Given this list of marker genes ZW10, TAOK3, WAC, MRNIP, INTS7, DGKZ, NSUN2, RPS27L, TAOK2, DNA2, TEX14, MAD1L1, HINFP, BUB1B, IK, STK38, TREX1, RNASEH2B, FBXO4, LYN, MAP3K20 (NCBI Gene Id 51784), TTI1, SPC25, CLOCK, PTPN11, NBN, NOP53, FOXO4, PLK1, CDT1, SYF2 (NCBI Gene Id 25949), SETMAR, CEP63, RFWD3, ORC1, KNTC1, SPDL1, PPP1R10, INCENP, BRD4 (NCBI Gene Id 90616), CDC6, PSMG2, DTL, NDC80, BRCC3, TIPIN, TTK, TPR, CLSPN, MSH2, TELO2, CDK5RAP3, BABAM1, NAE1, INIP, APC, LCMT1, KLHL22, DOT1L, BRIP1, HUS1B, SPC24, STK33, TRIAP1, TIMELESS, ETAA1, BIRC5, BABAM2, WDR76, RINT1, XPC, CRY1, UFL1, MAD2L2, CUL4A, MRE11, PRKDC, CCND1, CDC14B, BUB1, BUB3, RHNO1, CDK1, ZWILCH, SKA3, ATR, RAD17, ATRIP, NUF2, BARD1, PRP4K, RAD9B, MBTPS2, ZFYVE19, HORMAD1, DTX3L, CDK2, FZR1 (fizzy and cell division cycle 20 related 1), PARP9, PRPF19, CCAR2, INTS3, CCNB1, EME1, DUSP1 (dual specificity phosphatase 1), ATM, H2AX, FEM1B, NABP2, MAPK14, RAD51, DYNC1LI1, CDC45, TICRR, SKA1, BRCA1, XRCC3, E2F1, GIGYF2, CENPF (centromere protein F), KNL1, MBTPS1, ERCC6, CHFR, EIF2AK4, PLK3, BLM, CHEK2, RAD50, FANCD2, PROX1, FBXO6, ATF2, HASPIN, USP28, FBXO31, CDC5L, CDC20, TP53 (NCBI Gene Id 7157), TTI2, GEN1, TP53BP1, ABRAXAS1, TAOK1, PABIR1, EME2, RBBP8, RAD1, MAD2L1BP, TIPRL, CDKN1A, RPA2 (NCBI Gene Id 6118, replication protein A2), CHMP4C, DONSON (NCBI Gene Id 55597), MUS81, UIMC1, GNB1L, NABP1, BRCA2, ZWINT, USP44, CHEK1, HUS1 (HUS1 checkpoint clamp component), PRAP1, CDCA8, MDC1, MUC1, CAMSAP3, ANAPC15, FOXN3, IER3, BRSK1, SDE2, RAD9A, ZNF830, ZNF207, RPA4, VPS4A, MAD2L1, CDK5RAP2, TRIP13, TRIM39, NEK11, TOPBP1, AURKB (aurora kinase B), here is a description of the gene set: species: Homo sapiens Human Gene Set: GOBP_CELL_CYCLE_CHECKPOINT_SIGNALING A signaling process that controls cell cycle progression by monitoring the integrity of specific cell cycle events. A cell cycle checkpoint begins with detection of deficiencies or defects and ends with signal transduction.